The following is a description of a gene set: Mouse Gene Set: GOBP_GLUTAMATE_SECRETION The controlled release of glutamate by a cell. The glutamate is the most abundant excitatory neurotransmitter in the nervous system. studied in species Mus musculus, and this is the list of marker genes: Npy5r, Kcnk1, Stxbp1, Bdnf, Abcc8, Grm2, Apba1, Grm7, Syt4, Il1b, Myo6, Pianp, Grin2b, Adora2a, Trpv1, Avpr1a, Pak1, Nf1, Cck, Dpysl2, Ntrk2, Htr6, Slc38a2, Ntsr1, Snca, Dtnbp1, Avp, Adora1, Rab3gap1, Gabbr1, Gipc1, Trh, Kmo, Best1, Gja1, Nr3c1, P2rx7, Il1rn, Kcnk2, Prkg1, Kcnj8, Hrh3